Given this list of marker genes PLAGL1, HLA-DRB1, PART1, CYB5R3, CYP11B1, SLC25A24, BTN2A1, GIMAP6, HLA-DPA1, HLA-DRA, GRHL2, GLS, PAH, GLUL, CD7, C1QB, SUSD6, KTN1, DGAT1, APOL3, HLA-DPB1, HRC, APOE, TGFBR2, EMCN, here is a description of the gene set: Human Gene Set: WEST_ADRENOCORTICAL_CARCINOMA_VS_ADENOMA_DN Pediatric adrenocortical tumors (ACT) are rare and often fatal malignancies; little is known regarding their etiology and biology. To provide additional insight into the nature of ACT, we determined the gene expression profiles of 24 pediatric tumors (five adenomas, 18 carcinomas, and one undetermined) and seven normal adrenal glands. Distinct patterns of gene expression, validated by quantitative real-time PCR and Western blot analysis, were identified that distinguish normal adrenal cortex from tumor. Differences in gene expression were also identified between adrenocortical adenomas and carcinomas. In addition, pediatric adrenocortical carcinomas were found to share similar patterns of gene expression when compared with those published for adult ACT. This study represents the first microarray analysis of childhood ACT. Our findings lay the groundwork for establishing gene expression profiles that may aid in the diagnosis and prognosis of pediatric ACT, and in the identification of signaling pathways that contribute to this disease. from publication West AN, Neale GA, Pounds S, Figueredo BC, Rodriguez Galindo C, Pianovski MA, Oliveira Filho AG, Malkin D, Lalli E, Ribeiro R, Zambetti GP (PMID 17234769) Down-regulated genes in pediatric adrenocortical carcinoma (ACC) compared to the adenoma (ACA) tumors. species: Homo sapiens